The following is a description of a gene set: Any process that activates or increases the frequency, rate, or extent of interleukin-12 production. Mouse Gene Set: GOBP_POSITIVE_REGULATION_OF_INTERLEUKIN_12_PRODUCTION species: Mus musculus, and this is the list of marker genes: Ccl19, Il23r, Ifng, Laptm5, Tlr2, Tlr9, Clec7a, Scimp, Flt3, Syk, Tnfsf4, Ccr7 (C-C motif chemokine receptor 7), Hspd1, H2-M3, Irf8, Il12b, Tnfsf9, Tlr4, Ido1, Lep, Rel, Cd40, Irf1, Rela, Tnfsf18, Tirap, Il16, Plcg2, Mdk, Nod2, Ltb, Tlr6, Isl1, Cd36, Defb25, Hmgb1, Il17a, Ager, Unc93b1, Il23a, Mapk11, Mapk14, Tlr3, Cd40lg, Traf6, Plcb1